Given this list of marker genes Inpp5d, Cd24a, Gpr137, Hamp, P2rx7, Iapp, Cldn18, Grem1, Tmem119, Cartpt, Ubash3b, Gpr137b, Cyp19a1, Bcr, Vegfa, Cd38, Abr, Cst3, Gata4, Ypel4, Il6, Agt, Ceacam1, Pparg, Tnfrsf11b, Csk, Fshr, Sfrp1, here is a description of the gene set: Any process that stops, prevents, or reduces the frequency, rate, or extent of tissue remodeling. species: Mus musculus Mouse Gene Set: GOBP_NEGATIVE_REGULATION_OF_TISSUE_REMODELING